The following is a description of a gene set: Human Gene Set: REACTOME_RECOGNITION_AND_ASSOCIATION_OF_DNA_GLYCOSYLASE_WITH_SITE_CONTAINING_AN_AFFECTED_PURINE Recognition and association of DNA glycosylase with site containing an affected purine species: Homo sapiens, and this is the list of marker genes: H4C8, H2AC14, H2BC3, TINF2, H4C15, H2AC7, H2BC1, H2AB1, H3-4, H2AC19, H2BC15, H2BC12, H4C12, H4C6, H2BC14, H2AC18, TERF1, TERF2, H2BC7, H2BC4, H2AZ2, H2BC13, H2AJ, H4C4, H2BC9, H4C16, H2AC4, MPG, H2BC26, MUTYH, H2AC6, H2BC5, H4C9, H4C5, H2BC8, H4C14, ACD, POT1, H2AX, H2BC11, H2BC12L, TERF2IP, H4C3, H2BC6, H4C13, H2BC21, H2BC17, H2BC10, H4C2 (NCBI Gene Id 8366), H4C1, H4C11, OGG1, H2AC8, H2AC20, NEIL3